Given this list of marker genes SLC38A2, SLC6A15, SLC6A20, SLC38A1, SLC6A7, here is a description of the gene set: Human Gene Set: GOMF_PROLINE_SODIUM_SYMPORTER_ACTIVITY studied in species Homo sapiens Enables the transfer of a solute or solutes from one side of a membrane to the other according to the reaction: proline(out) + Na+(out) = proline(in) + Na+(in).